Given this list of marker genes SELENOV, ALOX15B, PRDX2, CAT, KMO, SERPINA3, NFKB1, GPX2, SAA3P, INS, SELENOW, GPX6, SCARB1, ALB, SELENOP, INSR, PNPO, TXNRD2, CCL2 (NCBI Gene Id 6347), CTH, SELENOT, F7, ALOX5AP, ICAM1, SELENOS, SOD2, HBA1, NFKB2, IFNG (NCBI Gene Id 3458), SAA2, TNF, CBS, GGT1, PTGS2, GPX4, GPX1, PRDX5, SELENON, LDLR, FGG (NCBI Gene Id 2266), TXN, PRDX4, SERPINE1, DIO3, PTGS1, TXNRD1, ABCA1, GSR, IL6, APOB, TXNRD3, PLG, SOD1, SELENOI, IL1B, SELENOO (selenoprotein O), DIO2, FGB, F2, MTHFR, MPO, SEPHS2, SOD3, SELENOM, RELA, SELENOK, FGA, RFK, GPX3, KYNU, HBB, SAA1, MSRB1, PRDX1 (peroxiredoxin 1), CRP, DIO1, ALOX5, SELENOF, FLAD1, APOA1, PRDX3, MTR, SAA4, SELENOH, XDH, PLAT, here is a description of the gene set: Human Gene Set: WP_SELENIUM_MICRONUTRIENT_NETWORK studied in species Homo sapiens Selenium micronutrient network